The following is a description of a gene set: species: Homo sapiens Human Gene Set: GOMF_RNA_EXONUCLEASE_ACTIVITY Catalysis of the sequential cleavage of mononucleotides from a free 5' or 3' terminus of an RNA molecule., and this is the list of marker genes: ISG20, ISG20L2, DCP2 (NCBI Gene Id 167227), NOCT, DIS3L, CNOT2, DIS3L2, CNOT6L, PAN3, EXOSC4, EXD2 (exonuclease 3'-5' domain containing 2), ERI1, ERI3, REXO2, PNLDC1, CPSF3, EXOSC2, CNOT1, ERI2, DIS3, EXOSC10, ZC3H12A, EXOSC3, PNPT1, EXOSC6, TOE1, XRN2, CNOT7, EXOSC5, EXOSC7 (NCBI Gene Id 23016), CNOT8, EXOSC8, POLRMT, PARN, DCPS, PDE12, PAN2, USB1, EXOSC1, EXOSC9, HELZ2, XRN1, CNOT6, MYG1